The following is a description of a gene set: studied in species Homo sapiens Any process that activates or increases the frequency, rate or extent of leukocyte degranulation. Human Gene Set: GOBP_POSITIVE_REGULATION_OF_LEUKOCYTE_DEGRANULATION, and this is the list of marker genes: GATA2, ADORA2B, STXBP1, FGR, ITGAM, VAMP7, FCER1G, PLA2G3 (phospholipase A2 group III), HLA-F, SPHK2, SYK (spleen associated tyrosine kinase), CD160, AP1G1, IL4R, GATA1, SNX4, GAB2, F2RL1, KLRC2, IL13, ITGB2, CD177, STX4, VAMP8, LAMP1